Given this list of marker genes RYR3, GSTM2, SELENON, SLC8A1, CACNA1S, RYR1, P2RY6, RYR2, TMEM38B, TMEM38A, P2RY1, CASQ2, TRPA1 (NCBI Gene Id 8989), here is a description of the gene set: Human Gene Set: GOBP_CELLULAR_RESPONSE_TO_PURINE_CONTAINING_COMPOUND Any process that results in a change in state or activity of a cell (in terms of movement, secretion, enzyme production, gene expression, etc.) as a result of a purine-containing compound stimulus. studied in species Homo sapiens